Given this list of marker genes NME1, NOB1, BZW2, TOMM40, TKT, PAICS, MYC, MT1G, REG4, POLD2, MRPL3, EIF4EBP1, AHCY, GNL3, RUVBL1, EEF1E1, STOML2, TOMM22, MRPS12, SRM, PRMT1, MRPL12, GCSH, AKR1B10, ALG3, NIFK, OLFM4 (NCBI Gene Id 10562), PHB1, F12, DCTPP1, ISOC2, FBL, CKMT1A, EXOSC5, EBPL, FABP5, IMPDH2, GPATCH4, EBNA1BP2, RSL1D1, NPM3, DKC1, TPPP3, CA2, MRPL24, NOP16, C1QBP, LYZ, TRAP1, CISD3, here is a description of the gene set: from publication Gavish A, Tyler M, Greenwald AC, Hoefflin R, Simkin D, Tschernichovsky R, Galili Darnell N, Somech E, Barbolin C, Antman T, Kovarsky D, Barrett T, Gonzalez Castro LN, Halder D, Chanoch-Myers R, Laffy J, Mints M, Wider A, Tal R, Spitzer A, Hara T, Raitses-Gurevich M, Stossel C, Golan T, Tirosh A, Suvà ML, Puram SV, Tirosh I (PMID 37258682) species: Homo sapiens Genes upregulated in subsets of cells of a given type within various tumors In this study, an extensive analysis was conducted to define meta-programs (MPs) capturing intra-tumor heterogeneity across a spectrum of tumor types. The approach utilized non-negative matrix factorization (NMF) to analyze each cell type separately within individual tumor samples. This involved the analysis of malignant cells, macrophages, fibroblasts, endothelial cells, epithelial cells, T-cells, and B-cells. NMF was executed with varying parameter values (K=4, 5, 6, 7, 8, 9), thereby generating 39 programs for each cell type per sample. Each NMF program was summarized by the top genes based on NMF coefficients.\nRobust MPs were then delineated for each cell type using a set of stringent criteria, including recurrence within the same tumor, similarity to programs in other tumors, and non-redundancy within a tumor. Subsequently, these robust NMF programs were clustered (per cell type) based on Jaccard similarity, leading to the identification of MPs associated with each cell type.\nTo enhance the quality of the MPs, a refinement steps were undertaken, involving the removal of MPs suspected of reflecting low-quality data (with an overrepresentation of ribosomal proteins or mitochondrial-encoded genes), single-study inclusion, or similarity to miss-annotated cell types. Human Gene Set: GAVISH_3CA_METAPROGRAM_EPITHELIAL_MYC